Given this list of marker genes CDKN2C, ZNRF3, NR3C1, PRKAR1A, MYT1L (NCBI Gene Id 4662), CDKN1B (NCBI Gene Id 1027), PRNP, PDE11A, HTR1A (5-hydroxytryptamine receptor 1A), CDKN2B, KDM1A, POR (NCBI Gene Id 96440), USP48, MEN1, CDKN2A, ARMC5, AIRE, GNAS, CTNNB1, RET, CYP11B2, BRAF, CYP11B1, KCNJ11, PRKACA, CDH23, ATRX, USP8, CYP21A2, TP53, CDKN1A, PDE8B, TERT, here is a description of the gene set: Overproduction of the hormone of cortisol by the adrenal cortex, resulting in a characteristic combination of clinical symptoms termed Cushing syndrome, with truncal obesity, a round, full face, striae atrophicae and acne, muscle weakness, and other features. Increased circulating cortisol level species: Homo sapiens Human Gene Set: HP_INCREASED_CIRCULATING_CORTISOL_LEVEL